The following is a description of a gene set: Human Gene Set: GOMF_TITIN_BINDING studied in species Homo sapiens Binding to titin, any of a family of giant proteins found in striated and smooth muscle. In striated muscle, single titin molecules span half the sarcomere, with their N- and C-termini in the Z-disc and M-line, respectively., and this is the list of marker genes: ANKRD23, CALM2, TCAP, ACTN2, CAPN3, CAMK2D, MYBPC3, ANKRD1, OBSCN, CALM3, TRIM63, MYBPC1, CALM1